The following is a description of a gene set: Human Gene Set: HP_ACHROMATOPSIA A condition where the retina contains no functional cone cells, so that in addition to the absence of color discrimination, vision in lights of normal intensity is difficult. studied in species Homo sapiens Achromatopsia, and this is the list of marker genes: ATF6, GNAT2, NBAS, CNGA3, CNGB3